Given this list of marker genes ACVRL1, MTMR4, PRMT1, HES1, SKOR2, MIR100, ABL1, FBXL15, SOST, MIR199B, SFRP4, FST, NEO1, SORL1, RBPMS2, GREM2, ITGA3, CHRDL1, MIR199A1, TBX20 (NCBI Gene Id 57057), MIR26A1, HOXA13, SCUBE3, BAMBI, KCP (NCBI Gene Id 378173), GREM1 (gremlin 1, DAN family BMP antagonist), PCSK6, CHRDL2, ENG, SMURF1, CER1, SOSTDC1, CAV1, ELAPOR2, NOTCH1, DLX1, VWC2L, DKK1, MIR98, PELO, SKI, TNFAIP6, SFRP2, SPART, SMURF2, FKBP8, ARK2C, ZNF423, MSX1, TOB1, FSTL3, SMAD5-AS1, FBN1, NGLY1, CRB2, FSTL5, GPC3, FZD1, SKOR1, BMPER, CCN1, RGMA, UBE2D3, MSX2, MIR106A, GPR155, FOXD1, MIR302C, PPM1A, HTRA1, DAND5, LRP2, NOG, CTDSPL2, LEMD3, FSTL4, GDF2, SULF1, CRIM1, NUMA1, FSTL1, MIR195, MIR20A, MICOS10-NBL1, RBPJ, NOTCH2, NBL1, VWC2 (von Willebrand factor C domain containing 2), SFRP1, ERFE, UBE2D1, KDR, MIR214, MIR125B1, UBE2O, HTRA3, WNT5A, SOX11, CHRD, SMAD6, MIR140, GDF5, TFAP2B, HES5, HIPK2, SMAD7, HJV, ILK, PPARG, CDH5, SKIL, XIAP, MIR210, WNT1, TMEM53, GDF3, MIR93, SMAD2, TRIM33, TWSG1, MIR885, TMPRSS6, GATA4, BMP4, here is a description of the gene set: studied in species Homo sapiens Human Gene Set: GOBP_REGULATION_OF_BMP_SIGNALING_PATHWAY Any process that modulates the frequency, rate or extent of the activity of any BMP receptor signaling pathway.